Given this list of marker genes RAB7B, TBC1D10C, RAB3GAP2, RIC1, DENND2B, RAB5C, TRAPPC9, RAB38, TBC1D3, RAB7A, DENND6A, RAB10, RAB11B, RIN2, DENND1B, DENND2C, RAB32, DENND5B, RAB5A, TRAPPC10, SBF2, HPS1, AKT3, RAB35, DENND1C, TBC1D14, TRAPPC2L, RAB27B, TRAPPC13, TBC1D24, CHM, RAB6B, RAB12, TRAPPC12, AKT1, RABGAP1, DENND4C, DENND4A, TBC1D15, RAB9B, TRAPPC4, TBC1D13, RAB1B, SYTL1, HPS4, CCZ1, ULK1, RAB11A, RAB33B, DENND5A, RAB18, GGA1, RAB21, GDI2, TRAPPC11, DENND2A, TBC1D10A, DENND3, RGP1, TRAPPC2, SBF1, GGA3, RAB6A, MON1A, DENND6B, TBC1D10B, YWHAE, GABARAPL2, OPTN, CCZ1B, MON1B (MON1 homolog B, secretory trafficking associated), RAB3A, POLG, RABEP1, MAP1LC3B, RAB27A, RINL, TBC1D25, RAB3GAP1, AKT2, TRAPPC3, RAB3IL1, RAB31, TRAPPC1, GAPVD1, GABARAP, RABGEF1, ANKRD27, RAB39B, RAB14, ALS2CL, TSC2, ALS2, TRAPPC8, RAB9A, RAB13, RIN3, TRAPPC5, DENND2D, DENND4B, DENND1A, TRAPPC6B, RAB8B (NCBI Gene Id 51762), TBC1D2, TBC1D20, TSC1, MADD, CHML, RAB8A, GDI1, TBC1D17, RAB1A, TBC1D7, RAB5B, TBC1D16, RIN1, RAB39A, RAB33A, RAB3IP, RAB4A, ARF6, TRAPPC6A, GGA2, here is a description of the gene set: part of: Membrane Trafficking Reactome Pathway: Rab regulation of trafficking species: Homo sapiens Human cells have more than 60 RAB proteins that are key regulators of intracellular membrane trafficking. These small GTPases contribute to trafficking specificity by localizing to the membranes of different organelles and interacting with effectors such as sorting adaptors, tethering factors, kinases, phosphatases and tubular-vesicular cargo. <br><br>RAB localization depends on a number of factors including C-terminal prenylation, the sequence of upstream hypervariable regions and what nucleotide is bound, as well as interaction with RAB-interacting proteins. More recently, the activity of RAB GEFs has also been implicated in regulating the localization of RAB proteins (Blumer et al, 2103; Schoebel et al, 2009; Cabrera and Ungermann, 2013; reviewed in Barr, 2013; Zhen and Stenmark, 2015).